The following is a description of a gene set: from publication Madan B, Madan V, Weber O, Tropel P, Blum C, Kieffer E, Viville S, Fehling HJ (PMID 19332562) Human Gene Set: MADAN_DPPA4_TARGETS Dppa4 (developmental pluripotency-associated 4) has been identified in several high-profile screens as a gene that is expressed exclusively in pluripotent cells. It encodes a nuclear protein with an SAP-like domain and appears to be associated preferentially with transcriptionally active chromatin. Its exquisite expression pattern and results of RNA interference experiments have led to speculation that Dppa4, as well as its nearby homolog Dppa2, might play essential roles in embryonic stem (ES) cell function and/or germ cell development. To rigorously assess suggested roles, we have generated Dppa4-deficient and Dppa4/Dppa2 doubly deficient ES cells, as well as mice lacking Dppa4. Contrary to predictions, we find that Dppa4 is completely dispensable for ES cell identity and germ cell development. Instead, loss of Dppa4 in mice results in late embryonic/perinatal death and striking skeletal defects with partial penetrance. Thus, surprisingly, Dppa4-deficiency affects tissues that apparently never transcribed the gene, and at least some loss-of-function defects manifest phenotypically at an embryonic stage long after physiologic Dppa4 expression has ceased. Concomitant with targeted gene inactivation, we have introduced into the Dppa4 locus a red fluorescent marker (tandem-dimer red fluorescent protein) that is compatible with green fluorescent proteins and allows noninvasive visualization of pluripotent cells and reprogramming events. Genes differentially expressed in ES cells with DPPA4 knockout. studied in species Mus musculus, and this is the list of marker genes: RHOXF1, HORMAD1, MYO1F (NCBI Gene Id 4542), TEX19, CYCTP, SNTB1, SNAP91, USP17L24, SPINK1, STK31, GTSF1, ABCB1, NAA11, DNAJC6, TTPA, SPESP1, DDX4, AARD, HOOK1, AURKC, MLLT6, TEK, CXorf49 (chromosome X open reading frame 49), FAM9A (NCBI Gene Id 286475), CLCA3P, SLC25A31, SOHLH2, GAD1, PDCL2, NDUFB11, CALB2, SHE, MAEL, FTHL17, PLEKHG1, KLHL13, SERPINB6, NEFH, SYCE1, HCK, IQCG, ACOT1, PRPF39, RASIP1, ZSCAN4, DAZL (deleted in azoospermia like), GPX2, CA4, MSANTD5, AP1S3, CFAP144, EIF1AY, GLI1, DPPA4, NEUROD1, PRRC1 (proline rich coiled-coil 1), REC114 (REC114 meiotic recombination protein), TUBA3D, MEP1B, RNF17, CHFR